Given this list of marker genes Hnf1a, Mfn1, Tmem135, Mtln, Bid, Nnt, Mfn2, Myc, Gsk3b, Akt1, Ctns, Ndufc2, Vcp, Bad, Prkn, here is a description of the gene set: Any process that activates or increases the frequency, rate or extent of establishment or extent of a mitochondrial membrane potential, the electric potential existing across any mitochondrial membrane arising from charges in the membrane itself and from the charges present in the media on either side of the membrane. studied in species Mus musculus Mouse Gene Set: GOBP_POSITIVE_REGULATION_OF_MITOCHONDRIAL_MEMBRANE_POTENTIAL